The following is a description of a gene set: Human Gene Set: MIR6802_5P from publication Chen Y, Wang X (PMID 31504780) studied in species Homo sapiens Genes predicted to be targets of miRBase v22 microRNA hsa-miR-6802-5p in miRDB v6.0 with MirTarget v4 prediction scores > 80 (high confidence targets)., and this is the list of marker genes: BBOF1, RBP3, MRPS33, FAM169BP, CCM2L, ELOVL1, NBR1, TTN, SLC35B4, CDC14B (NCBI Gene Id 8555), TUSC3, NOTCH2NLA, OCA2, TREML1, DTNB, FAM76B, ATXN7, SPEF2, RAB2B, EPHB1, UBAP2, STRN, TOM1L1 (target of myb1 like 1 membrane trafficking protein), EIF1AY, ASB3, DOCK8-AS1, NFASC, OAS1